The following is a description of a gene set: part of: Platelet activation, signaling and aggregation The platelet GPIb complex (GP1b-IX-V) together with GPVI are primarily responsible for regulating the initial adhesion of platelets to the damaged blood vessel and platelet activation. The importance of GPIb is demonstrated by the bleeding problems in patients with Bernard-Soulier syndrome where this receptor is either absent or defective. GP1b-IX-V binds von Willebrand Factor (vWF) to resting platelets, particularly under conditions of high shear stress. This transient interaction is the first stage of the vascular repair process. Activation of GP1b-IX-V on exposure of the fibrous matrix following atherosclerotic plaque rupture, or in occluded arteries, is a major contributory factor leading to thrombus formation leading to heart attack or stroke. GpIb also binds thrombin, at a site distinct from the site of vWF binding, acting as a docking site for thrombin which then activates Proteinase Activated Receptors leading to enhanced platelet activation. studied in species Homo sapiens Reactome Pathway: GP1b-IX-V activation signalling, and this is the list of marker genes: VWF, RAF1, PIK3R1, COL1A2 (collagen type I alpha 2 chain), GP1BB, GP9, GP1BA, YWHAZ, GP5 (glycoprotein V platelet, NCBI Gene Id 2814), SRC, FLNA, COL1A1